The following is a description of a gene set: part of: Transport of connexons to the plasma membrane Reactome Pathway: Microtubule-dependent trafficking of connexons from Golgi to the plasma membrane Through videomicroscopy, a saltatory transport of connexon vesicles along curvilinear microtubules from the Golgi to the plasma membrane has been observed. Such a transport system has been described for similar secretory vesicles. species: Homo sapiens, and this is the list of marker genes: TUBA3E, TUBA4A, TUBA1C, TUBA8, TUBA3C, TUBB2A, GJA1, TUBAL3, TUBB8B, TUBB2B, TUBA4B, TUBA3D (tubulin alpha 3d), TUBA1B, TUBB1, TUBB4A, TUBB6, TUBA1A, TUBB8, TUBB4B, TUBB3